The following is a description of a gene set: part of: N-glycan antennae elongation in the medial/trans-Golgi Reactome Pathway: Reactions specific to the hybrid N-glycan synthesis pathway The transfer of a bisecting GlcNAc by MGAT3 commits the pathway toward the synthesis of hybrid glycans, because MAN2 is not able to operate on bisected oligosaccharides. The expression of MGAT3 over MGAT2 in a tissue can regulate the synthesis of hybrid toward complex N-glycans. The addition of a GlcNAc between the two arms also prevents the action of MGAT4, MGAT5 and FUT8. studied in species Homo sapiens, and this is the list of marker genes: MGAT3